Given this list of marker genes Adcy7, Nppb, Adcy6, Gucy2f, Adcy9 (adenylate cyclase 9), Nppc, Gucy1a1, Pth2, Adcy5 (NCBI Gene Id 224129), Nppa, Gucy2g, Gucy2c, Gucy2d, Adcy3, Adcy4, Npr2, Adcy2 (NCBI Gene Id 238696), Gucy1b1 (guanylate cyclase 1, soluble, beta 1), Adcy8, Gucy2e, Adcy1, Npr1, Adcy10, here is a description of the gene set: species: Mus musculus Mouse Gene Set: GOBP_CYCLIC_NUCLEOTIDE_BIOSYNTHETIC_PROCESS The chemical reactions and pathways resulting in the formation of a cyclic nucleotide, a nucleotide in which the phosphate group is in diester linkage to two positions on the sugar residue.